Given this list of marker genes Macroh2a1, Sirt7, Tsix, Spi1, Sphk2, Sgf29, 4930402K13Rik, Samd1, Men1, Pabpc1l, Apobec2, Fam47c, Wdr5, Egr1 (NCBI Gene Id 13653), Znhit1, Ash2l, Tet1, Mir744, Wbp2, Fam47e, Ep300, Smarcd1, Ftx, Kat8, L3mbtl3, Padi2, Usp21, Smarcb1, Smarca4, Ctcfl, Aicda, Atad2b (NCBI Gene Id 97804), Atad2 (NCBI Gene Id 70472), Vps72, Kdm1a, Glyr1, Rbbp5, Alkbh4, Kdm1b, Ogg1, Atf2, Myocd, Nr3c1, Zmpste24, Dpy30, Apobec1, Alkbh1, Tet3, Kmt2a, Lcor, Trp53, Setd1a, Brd7, Apex1, Rbm14, Kat7, 4930480E11Rik, Kdm2a, Letmd1 (NCBI Gene Id 68614), App, Phf2, N6amt1, Trmt112, Tet2, here is a description of the gene set: Mouse Gene Set: GOBP_POSITIVE_REGULATION_OF_GENE_EXPRESSION_EPIGENETIC An epigenetic process that increases gene expression at specific genomic regions through chromatin remodeling either by modifying higher order chromatin fiber structure, nucleosomal histones, or the cytosine DNA demethylation. studied in species Mus musculus